Given this list of marker genes Ocstamp, Tyrobp, Dcstamp, Trem2, Adam9, here is a description of the gene set: Any process that activates or increases the frequency, rate or extent of macrophage fusion. Mouse Gene Set: GOBP_POSITIVE_REGULATION_OF_MACROPHAGE_FUSION studied in species Mus musculus